The following is a description of a gene set: from publication Konuma T, Nakamura S, Miyagi S, Negishi M, Chiba T, Oguro H, Yuan J, Mochizuki-Kashio M, Ichikawa H, Miyoshi H, Vidal M, Iwama A (PMID 21540074) Human Gene Set: GSE27786_CD8_TCELL_VS_NKCELL_UP Each fraction of mouse hematopoietic cells was purified by cell sorting from bone marrow of 8-week-old C57BL/6 mice, and its gene expression was analyzed. Genes up-regulated in comparison of CD8 T cells versus NK cells. species: Homo sapiens, and this is the list of marker genes: CDC14B, GRHPR, SRD5A2, RPL13A, UBE3D, CLPX, ZKSCAN1, POLR1C, EREG, CEP170B, NXPH2, NLK, VPS26B, TFF2, PDGFRA, PRPS2, KRBA1, ARL3, FLNB, TXK, HNRNPC, C3orf80, GRIN2C, TBRG4, MEN1, PTCHD4, USP38, C8G, ITGAE, NAP1L1, RNF146, EIF3G, CYTH1, PHOX2A, RRP15, NOB1, CLDN10, WHRN, CRBN, ANKRD55, DNAH8, GPR183 (G protein-coupled receptor 183), TOMM7, EARS2, TFAP2A, PDXP, TOP1MT, RBM22 (NCBI Gene Id 55696), GADD45GIP1, DVL1, PDCD6, RRAD, TRAF3IP3, PSMA3, MRPL38, NDRG3, AEN, CYP2U1 (cytochrome P450 family 2 subfamily U member 1), ESRRG (estrogen related receptor gamma), EEF1E1, CPLX2, SNN, DENR, COX20, ACP5, HIBCH, ADGRG5, MSH2, FAM118A, PAX6, GLT8D2, TTLL12, MPPE1, IKBKE, PSMD12, UTP3, MAB21L3, ABCB8, SLC39A14, RIT2, ANKRD31, FCHSD2, SEC61B, CHD3, TM4SF4, NTHL1, TTC3, SLC6A8, SKP1, CCDC87, STK4, MIF, ZNF654, NOP10, ANKMY2, MYBPC1, AKAP6, FASTKD3, ACOXL, MTHFD1L, METTL18, PDCD1, CRYZ, BOLA3 (bolA family member 3), RBM48, ZFP1, KIF21B, MAP2K6, PUS1, SMG1, TTC28, IFT56, ACAT1, SLC20A1, NKD2, DHX33, DNAAF4, ADI1, SERBP1, ZZZ3, RBM5, EIF3I, AUH, SDHA, TSSC4, FBXO32, SESN3 (NCBI Gene Id 143686), RSPH9, TRMT61A, BCLAF1, KCNAB2, COX16, NSUN2, SREK1, HEATR1, MECR, EVA1C, NAA10, GDAP1L1 (NCBI Gene Id 93987), TMEM87B, METTL17, CCT5, TFAM (NCBI Gene Id 8033, transcription factor A, mitochondrial), PMS1, MRPL47, C16orf54, RAD52, SAXO5, GGT1, TFB1M, SLC14A1, GIMAP6, USP7, SSC5D, C19orf48P, SZT2, TUBB2B, SIGLEC1 (sialic acid binding Ig like lectin 1), RMND5B, CDH15, PHGDH, TNRC6C, MAGEA11, CD164, TMEM42, PARK7, NCK2, SLC25A40, AMELX, HK1, SLC49A4, BCL9L, MBOAT4, IP6K2, PANK4, PPP6R1, TPR, AKIP1, GPR68, INTS9, TIMP2 (NCBI Gene Id 7077), EHD3, ETNK1, AP1AR, CIMIP6, MBOAT1, CHCHD4, NIP7, RPL22L1, F2R, SYT12, MOB2, ADAMTS16, DNAJC9, PDE11A, GJA10, ZNF169, RPL14, MYB